The following is a description of a gene set: Human Gene Set: GOBP_NAD_METABOLIC_PROCESS The chemical reactions and pathways involving nicotinamide adenine dinucleotide (NAD+), a coenzyme that interconverts with its reduced form, NADH, in many redox and catabolic reactions. studied in species Homo sapiens, and this is the list of marker genes: SLC25A13, SLC25A18, CD38, NADK2, SLC25A12, QPRT, KYNU, GPD2, NAPRT, IDO1, SLC25A11, GPD1 (NCBI Gene Id 2819), SARM1, ACMSD, GPD1L, MDH1, NAMPT, HAAO, NMNAT2, NADSYN1, MDH2, NMNAT1, AFMID, GOT2, ASPDH, MACROH2A1, IDO2, NMRK1, GOT1, NADK, NUDT17, NUDT12, SLC25A22, NMNAT3, KMO, NMRK2, LDHB